The following is a description of a gene set: Genes down-regulated in follicular B lymphocytes versus marginal zone B cells. Bcl6 germline deletion causes a prominent inflammatory disease, owing to over-expression of Th2 cytokines, and affects the properties of B cells prior to immunization. Therefore we established the B cell-specific Bcl6 deletion mice and analyze the gene expression of naive B cells under physiological conditions. Human Gene Set: GSE28737_FOLLICULAR_VS_MARGINAL_ZONE_BCELL_DN from publication Kaji T, Ishige A, Hikida M, Taka J, Hijikata A, Kubo M, Nagashima T, Takahashi Y, Kurosaki T, Okada M, Ohara O, Rajewsky K, Takemori T (PMID 23027924) species: Homo sapiens, and this is the list of marker genes: RIGI, LBP, PFKP, CD200R1L, SMCO1, APAF1, FGFR3, LDB3, DUSP28, LRP8, SHOX2, XPO1, SIK3, LIPC, VPS54, IL33, DPYD, DCLK2, ICAM1, TREML2, CGGBP1, KRT72, SH3GL3, C3 (NCBI Gene Id 12266), CLEC14A, ATP6V0A1, EFNA1, TFAP2B, ATP2B2, CABP4, CHCHD2, BBS7, LRRC69, NCOA1 (nuclear receptor coactivator 1), GSDMD, SAMD9L, SPPL2A, CNOT11, GCH1, NXNL2, TAPBPL, C7orf57, SLC25A44, IRF2, EN2, CDKN1A, TENT4A, COL4A3, FBXO11, SLC23A1, RARB, DBH, KRT222, ANXA3, CD8B, CCND2, VAX2, GOT1, NLRP14, CACHD1, FADS1, IFIT1B, MEIS2, B3GNT3, SMPX (NCBI Gene Id 23676), SLC28A2, NET1, CMPK2, NONO, ST8SIA2, CALHM6, MATCAP2, IRGM, HOOK2, SSTR2, GABRD, MEX3B, TBC1D4, AK4, PSMB4, VSX2, SCARF1, HSF5, STAT2, MLPH, CES3, CCT3, CXCR5, PLAAT3, KRT84, ATOH8, CAPG, AMTN, SNX2, UNC13B, TEX12, AMN1 (NCBI Gene Id 196394), SLC16A11, MINK1, SYT4, SYNJ2, CCKBR, EDNRB, OLFM1, KAT2B, TMC8, RNF152, TAT, KIF26A, SASS6, ATP1A3, BIRC2, LIMS2, HOOK3, ARG2, ENTPD3, JCAD (junctional cadherin 5 associated), SLFN13, PCDH18, GPR174, MFAP5, ROBO2, USP25, CXCL14, HTR1B, RIT2, NIPAL1, SLC22A23, PHF20L1, BMX, FKBP6, GRHL3, TSPAN15, KCMF1, CA12, INKA1, SRRM4, CITED2, MID1, BHLHE40, DRAM1, FRMD4A, ANKS1B, KHDRBS3, PI4K2B, EDEM1, APOOL, BTG3, CAAP1, CALB1, BLOC1S6, CTDSPL2, ETV3, FBP2, DYNC1I1, GFRA1, BOK, CGREF1, LRCH2, C3orf80, LITAF (lipopolysaccharide induced TNF factor), IRX1, NEU3, COL27A1, RTP4, ZNFX1, SERPINH1, EFNA5, CCDC138, EVPL, MED12L, ALPK2, LY86, SCIN, MPL, GADD45A, PARP9, NCOA2, GABRG1, DUSP4, GPR45, SLAMF9, NTNG1, HELZ2, GRID1, CD40, TOGARAM2, NHSL3, AK5, TRPC5, DENND1B, RCOR2, ARMCX3, P2RY10, TNPO1, ENAM, CFAP251, RHCG, MAX, GGT1